Given this list of marker genes MTFP1, HADH, MTIF3, EPDR1, ITGB1, SMOC2, MMP13, TIMP1, SSPN, LY6E, TPST2, COL1A1, EMILIN1, BEND5, DNAJC15, ALDOC, LOXL4, PALLD, ATP5F1C, RNF181, RCN3, MYL6, IFITM2, OMD, MYO1B, FLNB, FAT1, GTF2H5, NDUFB4, GALNT1, TNFAIP6, ASPN, COPZ2, SERPINF1, PDLIM7, TAX1BP3, SERPING1, RAP1B, LRP1, SP100, TCF4, IDH3G, CTSK, HSPG2, TMEM119, ITGBL1, TRIP6, CAMTA1 (NCBI Gene Id 23261), MYL9, ZSCAN16-AS1, C1QTNF1, PLAAT3 (phospholipase A and acyltransferase 3), PLEKHA5, GPC4, PDGFRA, ESD, ANKRD37 (ankyrin repeat domain 37), INAFM1, ETFB, EPB41L2, PDGFRB, RUNX2, EMP2, IFITM1, FGF7, CTSF, RAB34, BDH2, MPHOSPH8, EGLN3, ITGA11, MGMT, TMEM256, PCOLCE, SFT2D1, CPXM2, PTGDS, DTWD1, MRC2, HPCAL1, SFRP4, ZFP36L1, ITGB5, PDLIM4, TIMP2, UNC5B (NCBI Gene Id 23663), ESF1, TPM1, FAM13A, FSTL1, ATP5IF1, RNASEH2C, RARRES2, PDGFRL, BAD, SH3PXD2A, OPTN, TIMM8B, SOX4, ENPP2, PNISR, GSTM3, PTH1R, CERCAM, PSMB8, SAT2, MYLIP, FNDC1, VAMP5, DCTN3, CHD9, R3HCC1, INTU, PFN2, VAMP2, IBSP, ALPL, ADK, PGAM2, ILK, CUEDC2, HSBP1L1 (NCBI Gene Id 440498), MRPL14, NUDT1, TPM2, MXRA8, IGFBP4, LIMA1, PGAM1, LAMB2, CHAD, GSTO1 (NCBI Gene Id 9446), CNN2, DMAC1, SOD3, UACA, ZNHIT1, IFITM5, SLC29A1, FBN1, DLX5, CDC42EP1, GNG11, JAM2, SMCO4, PDLIM2, AAMDC, BICC1, TCEA3, ECM2, HTRA1, RNF5, ZNF292, MMP2, NOL3, MEF2C, DPCD, C1S, ARL3, AEBP1, TP53I11, CSNK2B, PLS3, SLC44A1, LUM, CALD1, RPF2, THBS2, COX6A2, DPYSL3, S100A16, here is a description of the gene set: from publication Su Z, Ho JWK, Yau RCH, Lam YL, Shek TWH, Yeung MCF, Chen H, Oreffo ROC, Cheah KSE, Cheung KSC (PMID 38267611) studied in species Homo sapiens The transformation of benign lesions to malignant tumours is a crucial aspect of understanding chondrosarcomas, which are malignant cartilage tumours that could develop from benign chondroid lesions. However, the process of malignant transformation for chondroid lesions remains poorly understood, and no reliable markers are available to aid clinical decision-making. To address this issue, we conducted a study analysing 11 primary cartilage tumours and controls using single-cell RNA sequencing. By creating a single-cell atlas, we were able to identify the role of endoplasmic reticulum (ER) stress in the malignant transformation of conventional central chondrosarcomas (CCCS). Our research revealed that lower levels of ER stress promote chondrosarcoma growth in a patient-derived xenograft mouse model, while intensive ER stress reduces primary chondrosarcoma cell viability. Furthermore, we discovered that the NF-?B pathway alleviates ER stress-induced apoptosis during chondrosarcoma progression. Our single-cell signatures and large public data support the use of key ER stress regulators, such as DNA Damage Inducible Transcript 3 (DDIT3; also known as CHOP), as malignant markers for overall patient survival. Ultimately, our study highlights the significant role that ER stress plays in the malignant transformation of cartilaginous tumours and provides a valuable resource for future diagnostic markers and therapeutic strategies. Human Gene Set: SU_HO_CONV_CENT_CHONDROSARCOMA_C2_STROMAL Characterized by markers (e.g., COLIAI/Collagen I, LUM, and PCOLCE) enriched in extracellular matrix organisation, ossification, biomineralization, and skeletal system development. No evidence of significant CNV was found in the Stro cluster of CCCS, supporting the annotation of tumour associated stromal cell population.